The following is a description of a gene set: studied in species Homo sapiens Human Gene Set: GOMF_SEMAPHORIN_RECEPTOR_BINDING Binding to a semaphorin receptor., and this is the list of marker genes: SEMA4A, SH3BP1, SEMA4G, SEMA3A, SEMA4D, SEMA3F, PLXNB1, SEMA3G (NCBI Gene Id 56920), SEMA6C, SEMA6D, SEMA4C, SEMA5B, SEMA3E, SEMA5A, SEMA6A, SEMA4B, SEMA3C, TREM2, SEMA3B, SEMA7A, RIT2, SEMA3D, SEMA4F, SEMA6B